The following is a description of a gene set: Any process that modulates the frequency, rate or extent of the hydrolysis of a peptide bond or bonds within a protein. Human Gene Set: GOBP_REGULATION_OF_PROTEOLYSIS species: Homo sapiens, and this is the list of marker genes: SPOCK2, CLEC3B, GPLD1 (NCBI Gene Id 2822), HSPBP1, BAD, ZER1, UBE2K, PTK2, EFNA1, PSMC4, GBA1 (glucosylceramidase beta 1), SVIP, PHF20L1, TMTC3, USP17L2, UBQLN1 (ubiquilin 1), PRKACA, MIR128-1, CLN3, CSNK2B, RBX1, AURKAIP1, AGBL4, RPL11, CBFA2T3, EPHA4, ADAM8, SH3D19, TM4SF20, CR1, STUB1, CRB2, CST4, BAG5, ARAF, PLAU, USP25, MDM2, PSMC3, DDA1, GRN, PLAUR, GPX1, SPOCK3, IDE, MTM1, ACP4, ZFAND2A (NCBI Gene Id 90637), DNAJC1, PIAS1, TNP2, GAS1, CDK5RAP3, MELTF, IL33, GSK3B, MARCHF7, AURKA, PRSS22, CDKN2A, PABIR1, SH3RF2, BAG6 (BAG cochaperone 6), RGMA, CDK5, ATP13A2, USP38, PSME3, CSNK2A1, ELOB, RNFT2, FOXF2, CAMLG, CAPN3, TNF, NLRC4, DAB2IP, KCNE2, TSPAN17, LDLRAD3, IL10, TLK2, AQP11, WNT1, NEDD8, USP5, BBS7, PML, RFPL1, RECK, SERPINB3, IFT52, IL1B, UBXN2A, PYHIN1, COP1, DAB2, SUMO1, ENO1, CCDC22, ATP5IF1, CSNK1E, PLAT, PRICKLE1, GCLC, ALAD, APP, RPL5, UCHL5, HPN, RPS6KA2, HSPA1A, USP7, CSTB, MIR126, IL1R2, MIR152 (microRNA 152), ADRA2A, SERPINF2, TIMP1 (TIMP metallopeptidase inhibitor 1), CFL1 (NCBI Gene Id 1072), SNX9, SVBP, PSME3IP1, F2, FBXO22, PINK1, RACK1, TBC1D10A, TAF1, ASTL, KEAP1, THBS1, USP14, NR1H3, RUNX1, FMR1, WAC, RPS7, TSPAN15, PRNP, PRKN, PITHD1, AGTPBP1, TNFRSF1B, FBXW7, PSMD10, TRIB2, UBQLN2, CTSC, SEMG1 (semenogelin 1), SPON1, ADAM9, PKD1, SOCS4, TRIM32, CLN6, TMX1, TRIB1, CAV3, USP19, HAMP, TRIM39, CLU, DVL1, SPOP, CSNK2A2 (NCBI Gene Id 650690), CCBE1, DESI1 (desumoylating isopeptidase 1), RNF185, DNAJB2, FURIN, UBE3A, HIPK2, XPO1, SRC, PRELID1, NFE2L1, SPINK5, BAG2, DDRGK1, PSMD14, PSMC6, PDCL3, IFNG (interferon gamma), GIPC1, SOCS5, WFS1, ANXA2, L3MBTL3, SNX12, PRKACB, SERPINB13, SNX33, GLMN, CCAR2, F8A1, SERPINE2, PRKCG, UFL1, PTPN3, VTN, UBXN1, HECTD1, SMURF1, FBXW11, ASPH, STYX, RNF139, CDC20B, RAD23B, BAK1, LAMP3, LRRK2, RCHY1, TRIB3, TTC36, PLK3, MAPK9, PSMC5, OGT, TMEM259, TRIM67, SIRT2, PTK2B, SUFU, MAGEA3, PSMC2, FBXW8, NUPR1, S100A10, PARL, CHAC1, SIRT4, EIF3H, FETUB, LATS1, OSBPL7, NLRP7, RHBDD1, ATXN3L, GABARAP, NUDT15, VSIR, RHOBTB3, HDAC2, PTPN1, GSK3A, IST1, CHFR, F8A3, GAPDH, UBB, SENP1, F8A2, USP13, C2CD3, AKT1, ECM1, PRSS37, SMARCC1, ANGPTL8, SUMO2, PACSIN3, CLN8, SERPINB4, SIRT6, LRIG2, PLGRKT, TIMP2, SH3RF1, HSP90AB1, DET1, ATXN3, BTRC, SIRT1, KNG1, SGTA, GSAP, KLKB1, CDK2, TMF1, PTEN, TRAF7, OPHN1, GABARAPL2, MMP14, COMMD1, SERPINB9, PSENEN, TNP1, HDAC6, FADD, PSMF1, IKBKG, APOE, TMEM98 (NCBI Gene Id 26022), CAV1, GSN, INPP5B, SMAD7 (SMAD family member 7), NUB1, PSMC1, RFX4, PSME1, UBQLN3, EPPIN, DISC1, TP53, NR1H2, TF, BCAP31, PSME2, AXIN2, RNF180, RAD23A (NCBI Gene Id 5886), CNTN2, TRAF3, CSNK1D, MTOR, SERPINB1, ECSCR, ARHGAP5-AS1, ZNF418, TIMP4, TMEM168, MYH9, NEURL3, PAQR3, F12, SPOPL, A2ML1, VCP, TANK, HERPUD1 (homocysteine inducible ER protein with ubiquitin like domain 1), PRMT6, EGF, CSNK1A1, PANO1, FGFR4, RNFT1, TSPAN5, TAF9, CEBPA, AXIN1, PERP, LAPTM5, CDC20, NFE2L2, SERPINB8, PARK7, HFE, CSTA, SERPINE1, NKD2, TIMP3, PBK (NCBI Gene Id 55886), CWH43, TGFB1I1, KLHL40, MAP1A, CYFIP2, RCN3, RPL23, ZYG11B, FHIT, PSEN1, MBP, ROCK1, GNA12, UFSP2, PLK1, SHH (sonic hedgehog signaling molecule), SH3RF3, RYBP, DNAAF4, GLG1, N4BP1, PABPN1L, QRICH2, UBQLN4, NRDC, NOP53, CTSZ, RHBDF1, USP9X, CASP8, WNT10B, HSPA1B (NCBI Gene Id 3304), EPM2A, XBP1, SEMG2, FZR1, USP26, CST3, TREM2 (triggering receptor expressed on myeloid cells 2)